Given this list of marker genes PCDH17, IRF1, CAST (NCBI Gene Id 831), ATP6V0B, CFL1, LDHA (lactate dehydrogenase A), MAX, BAG3, IFITM3, MBNL1, LAP3, RNPS1, GBP2, TOP1, ARHGAP29, HLA-A, TPM3, SELE, NUDC, MYCT1 (NCBI Gene Id 80177), TNFRSF1A, FKBP4, SRSF4, ARL4A, IRF7, CHMP5, SH3BP5, IER3, AQP1, DNAJA1, HHEX, CDKN1A, TNFRSF12A, FLOT1, NFIB, ARGLU1, SNRPB, NANS, ARID5A, OAZ2, LIMS1, HNRNPM, PCAT19, PICALM, SPARCL1, NOP10, ITPRID2, ARL6IP1, CD74, MT-ND1, CALR, CLEC14A, FXYD5, POMP, TUBB6, SNHG7, CNIH1, EFNA1, LAMA4, DNAJB4, FAM241A, EIF2S1, CLEC2B, MT2A, LRRC8C, TGIF1, BMPR2, XRN2 (NCBI Gene Id 22803), JAK1, ARHGDIA, HLA-E, BRD2, ZFAND5, ZNHIT1, ANXA2, ANKRD11, CREBRF, DEPP1, HMOX1, NME1, NAMPT, SYNE2, INSIG1 (insulin induced gene 1), NCK1, STOM, HLA-DMA, SLIRP, B2M, SSU72, SYPL1, GNG12, SRSF5, CYTOR, CD55, HNRNPF, MRPL32, AP1S2, DDX21, MEF2C, ADAR, ICAM1, MTHFD2, ISG15, HLA-C, SMAD1, ANGPT2, CD59, UBE2J1, HMGA1, EIF3I, EIF3J, YBX3, GASK1B, ARID4B, ENG, RAC1, UBE2D3, IGFBP7, TFPI, TCP1, PSMD12, PGK1 (NCBI Gene Id 5230), MAP1LC3B, BCAM, SOX17, TNFSF10 (TNF superfamily member 10), PIM3, LMNA, ENO1, TMEM255B, PLEKHO1, S100A16, SERTAD1, CCN2, PDLIM1, RAB11A, GPX1, VWF, SLC38A2, SOD2, SYNCRIP, PDLIM5, AHSA1, PRDX1 (NCBI Gene Id 5052), PLPP3 (phospholipid phosphatase 3), HLA-B, THBS1, ETS2, HSPB1, CCDC85B, UBC, CAPZA2, BNIP2, CEBPD, SLC3A2, EPAS1, CARHSP1, STAT3, FCGRT (Fc gamma receptor and transporter), A2M, SAFB2, GIMAP6, TPT1, CHIC2, ELF1, NDRG1, DEK, VGLL4, IFIT1 (NCBI Gene Id 8374), ACKR1, ATP1A1, TMEM165, FTL, IFNGR1, SP100, MX1, GRPEL1, STING1, ARPC1B, MT-ND2, IFI44L, CDC37, CALCRL, MGAT1, EMP1, LUC7L3, CNKSR3, GIMAP7, BTG1, SNX3, SOCS3, SLC25A37, PLSCR1 (NCBI Gene Id 5359), CRIP2, NECTIN2, GNG5, SWAP70, EIF2AK2, CAV1, TM4SF1, TOPORS, MSN, GBP1 (NCBI Gene Id 2633), EHD4, LIFR, CRIM1, ANKRD12, EIF5A, RBMS1, SFPQ, ELOC, PPFIBP1, EIF2S2, MRPL14, PRRC2C, HSPA2, TMEM70, FKBP1A, HSPA1A, NFKBIA, MIR4435-2HG, MTUS1 (microtubule associated scaffold protein 1), RSRP1, DDX39A, PRSS23, ARRDC3, MRPL33 (mitochondrial ribosomal protein L33), GIMAP4, TCF4, NUPR1, NDUFV2, PSMB8, CFLAR, CSNK1A1, NCOA7, GNG11, BACE2, IFITM2, PPA1, NAPA, SRSF2, SPARC, RDX, MGP, TRIR, FNIP1, ANXA1, EIF4A1, ACTN1, APP, TUBA1C, LRRFIP1, MAFF, DAB2, TXN, SLC2A3, SERBP1, SPTBN1, NEAT1, SOCS2, WDR43, LDB2, UBE2B, PTPRB, ABL2, FOXP1, UBB, RCN1, GNAS (NCBI Gene Id 82944), CLIC2, DDX3X, BAZ1A, IFIT3, COX17, ANKRD28, TXNRD1, HSPD1, HLA-DRB1, IFI27, IFI6, PLIN2, ATF4, CLDN5, CAV2, IFITM1, POLR2L, MAST4, DNAJB6, YTHDF2, NASP, MT-ND3, WTAP, ARPC5L, PLS3, SAT1, HLX, SQSTM1, EMCN, RPL7L1 (ribosomal protein L7 like 1), SNU13, LGALS3, RAB5A, G3BP1, MAP2K3, ITM2A, PPP1R15A, TSC22D1, PPP3CA, ANXA5, SASH1, KLF6, CCDC50, PSMA7, ESAM, SPAG9, SINHCAF, HIF1A, GADD45A, CHMP4B, GABARAPL2, LUZP1, CLU, GSN, RBM8A, CTNNA1, CRBN, ERG, PARP14, ZNF385D, MGST2, MYL12A, ADGRL4, NOP16, TAGLN2, RAB7A, PHACTR2, PLEKHB2, TM4SF18, CTHRC1, LPAR6 (NCBI Gene Id 10161), RHOC, MAT2A, WWTR1, C1QBP, IL6ST, TUBB4B, VMP1, ACTN4, NNMT, EIF5B, SDCBP, UGCG, GIMAP8, ENY2, KRT18, PNP, PSME2, HSPE1, YPEL2, NPDC1, CDC42EP3, IFI16, HLA-DRB5, TAP1, RAB5C, here is a description of the gene set: species: Homo sapiens We identified three separate clusters (CL) of endothelial cells (CL7, CL9, CL16) expressing markers associated with lymph and blood vascular system (such as PECAM1, CD34, CTGF), but also associated with remodeling and inflammatory response (such as TXNIP, ANGPT2) (Fig. 3a-d). The DEGs of CL7 (such as CCL14, SOCS3, EGFL7) and CL16 (such as CCL21, TFF3) are linked to angiogenesis and lymphatics, respectively, while DEGs of CL9 (TM4SF1, NMMT) were more related to regulation of apoptosis (Fig. 3c, d). from publication Fan X, Bialecka M, Moustakas I, Lam E, Torrens-Juaneda V, Borggreven NV, Trouw L, Louwe LA, Pilgram GSK, Mei H, van der Westerlaken L, Chuva de Sousa Lopes SM (PMID 31320652) Human Gene Set: FAN_OVARY_CL9_PUTATIVE_APOPTOTIC_ENDOTHELIAL_CELL